Given this list of marker genes Rpa1, Mms22l, Rad51, Rmi1, Rec8, Rad51b, Ubqln4, Helq (helicase, POLQ-like), Mcm2, Gins2, Mad2l2, Shld2, Rfwd3, Wrn, Wdr48, Ints3, Ooep, Abl1, Atm, Cdc7, Ercc5, Hdgfl2, Csnk2a1, Sem1, Rad21l, Ep400, Zmynd8, Rad51ap1, Hus1, Nipbl, Aste1, Mcm6, Xrcc6, Rnf138rt1, Smc5, Rnf138, Yy1, Setd2, Polq, Recql, Xrcc5, Ppp4r2, Kat5, Brd8, Mrnip, Vps72, Psmd14, Rnf169, Poln, Rad21, Rmi2, Nsmce2, Recql5, Nucks1, Kmt5a, Ercc4, Timeless, Nabp2, Exd2, Xrcc2, Smchd1, Wrap53, Crebbp (NCBI Gene Id 547230), Fus, Dmap1, Ap5z1, Actb (actin, beta), Smc6, Tonsl, Shld1, Slx1b, Mcm3, Nsmce1, Morf4l1, Rpa2, Klhl15, Brca2, Ing3, Arid2, Fbh1, Cdc45, C1qbp, Pogz, Rad51c, Fancm, Skp2, Nabp1, Brme1, Fignl1, Parpbp, Sfpq, Rad54l, Slx4 (SLX4 structure-specific endonuclease subunit homolog (S. cerevisiae)), Tex15, Fancb, Mbtd1, Rad52, Epc2, Kdm4d, Zswim7, Mcm8, Hus1b, Swi5, Senp3, Ppp4c, Peli1, Mre11a, Ruvbl2, Blm, Palb2, Rad54b, Cgas, Rnf8, Htatsf1, Khdc3, Spidr, Morf4l2, Chd4, Ino80, Shld3, Helb, Rad50, Epc1, Chek1 (NCBI Gene Id 97555), H2ax, Ercc6, Actr2, Mcm5, Prmt1, Ube2n, Yeats4, Xrcc1, Pias4, Gins4, Rnf126 (NCBI Gene Id 70294), Mcm7, Rad51d, Trp53bp1, Mcm9, Xrcc3, Recql4, Swsap1, Rhno1, Rbbp8, Mcm4, Zfp365, Kdm1a, Dmc1, Mcmdc2, Poll, Fan1, Parp1, Topbp1, Zgrf1 (zinc finger, GRF-type containing 1), Plk1, Inip, Actl6a, Meiob, Top3a, Rtel1, Meaf6, Ankle1, Usp51, Ap5s1, Mrgbp, Aunip, Zfyve26, Gen1, Radx, Rev3l, Sfr1, Sirt6, Nbn, Rif1, Terf2ip, Was, Brca1, Samhd1, Ruvbl1, Kash5, Trrap, Mus81, Hrob, Rpa3, here is a description of the gene set: Mouse Gene Set: GOBP_RECOMBINATIONAL_REPAIR A DNA repair process that involves the exchange, reciprocal or nonreciprocal, of genetic material between the broken DNA molecule and a homologous DNA region. species: Mus musculus